Given this list of marker genes Rab5a, Nf1, Slc17a8, Dvl1, Syn1, Vps18, Rims4, Gper1, Itgb3, Fmr1, Gdnf, Tprg1l, Kmo, Asic1, Sv2b, Git2, Syt13, Nat8l, Ica1, Ncs1, Mctp1, Camk2a, Fev, Mef2c, Gpm6b, Tspoap1, Micu3, Stxbp5, Dtnbp1, Itgb1, Slc18a3, Prkcg, Atp2a2, Lrrk2, Ptger4, Drd3, Rap1a, Stxbp5l, Kcnh1 (NCBI Gene Id 16510), Tacr2, Nlgn1, Slc18a1, Rhot1, Stx1b, Syt4, P2ry4, Rims2, Prkn, Prkcb (protein kinase C, beta), Ppp1r9a, Tor1a, Syt1, Syt5, Stxbp1, Drd2, Snapin, Ppfia2, Rab3gap1, Cask, Cacna1d, Per2, Flot1, Snca, Unc13b, Slc30a1, Syt2 (NCBI Gene Id 96937), Gpr158, Cacna1a, Baiap3, P2rx2, Sphk1, Prkca, Rims3, Ngf, Sv2c, P2rx7, Slc10a4, Rims1, Ntrk2, Npy1r, Grm8 (NCBI Gene Id 269835), Rab3b, Nos1, P2ry2, Htr6, Npy (NCBI Gene Id 68398), Cacnb4, Cplx4, Kcnc4, Pfn2, Gpr151, Htr1d, Chrna3 (cholinergic receptor, nicotinic, alpha polypeptide 3), Unc13a (NCBI Gene Id 73695), Fbxo45, Hcrt, Drd4, Edn3, Dnm1l, Bcl2l1, Cplx3, Htr2c, App, Stx1a, Mctp2 (multiple C2 domains, transmembrane 2), Syngr3, Slc18a2, Sncg, Htr1b, Snap29, Wnt7a, Rab3a, Braf, Kcnc3, Gfap, Ggcx (NCBI Gene Id 56316), Cacna1b, P2ry1, Sncaip, Rap1b, Arl6ip5 (ADP-ribosylation factor-like 6 interacting protein 5), Adora2a, Git1, Bglap2, P2rx1, Syt8, Slc38a2, Slc4a8, Prepl, Fbxl20, Bglap, Pnkd, Cacna1e, Cspg5, here is a description of the gene set: Any process that modulates the frequency, rate or extent of the directed movement of a neurotransmitter into, out of or within a cell, or between cells, by means of some agent such as a transporter or pore. species: Mus musculus Mouse Gene Set: GOBP_REGULATION_OF_NEUROTRANSMITTER_TRANSPORT